The following is a description of a gene set: Human Gene Set: GOCC_LAMININ_COMPLEX A large, extracellular glycoprotein complex composed of three different polypeptide chains, alpha, beta and gamma. Provides an integral part of the structural scaffolding of basement membranes. studied in species Homo sapiens, and this is the list of marker genes: LAMA5, LAMA3, LAMA1, LAMC1, LAMC2 (NCBI Gene Id 3918, laminin subunit gamma 2), LAMB1, NTN4, LAMB2, LAMB3